The following is a description of a gene set: Foxp3+CD4+CD25+ regulatory T (T(reg)) cells are essential for the prevention of autoimmunity. T(reg) cells have an attenuated cytokine response to T-cell receptor stimulation, and can suppress the proliferation and effector function of neighbouring T cells. The forkhead transcription factor Foxp3 (forkhead box P3) is selectively expressed in T(reg) cells, is required for T(reg) development and function, and is sufficient to induce a T(reg) phenotype in conventional CD4+CD25- T cells. Mutations in Foxp3 cause severe, multi-organ autoimmunity in both human and mouse. FOXP3 can cooperate in a DNA-binding complex with NFAT (nuclear factor of activated T cells) to regulate the transcription of several known target genes. However, the global set of genes regulated directly by Foxp3 is not known and consequently, how this transcription factor controls the gene expression programme for T(reg) function is not understood. Here we identify Foxp3 target genes and report that many of these are key modulators of T-cell activation and function. Remarkably, the predominant, although not exclusive, effect of Foxp3 occupancy is to suppress the activation of target genes on T-cell stimulation. Foxp3 suppression of its targets appears to be crucial for the normal function of T(reg) cells, because overactive variants of some target genes are known to be associated with autoimmune disease. from publication Marson A, Kretschmer K, Frampton GM, Jacobsen ES, Polansky JK, MacIsaac KD, Levine SS, Fraenkel E, von Boehmer H, Young RA (PMID 17237765) Genes up-regulated by FOXP3 in both ex vivo and hybridoma cells. Human Gene Set: MARSON_FOXP3_TARGETS_UP species: Mus musculus, and this is the list of marker genes: SLC2A3, MALAT1, ENO3, S100A6, MYO1C, CD44, RGS16, CD81, PNP, MAPRE2, CSNK1D, HNRNPLL, TNK2, PDLIM2, NRIP1, STK10, EPHX1, RCSD1, NHERF1, RAC2 (NCBI Gene Id 5880), MCL1, VIM, IRF8, HACD3, LRRC8C, NCF4, DDIT4, PLIN2, CAPG, PSMB8, CELF2, RAMP1, PPM1B, ITGAV, ARHGAP9, TGFBR1, CRIP1, SERINC3, ETS1, RSRP1, ECM1, OSBPL9 (oxysterol binding protein like 9, NCBI Gene Id 79638), MBNL2, MKNK2 (MAPK interacting serine/threonine kinase 2), CYB5A, TNFRSF4, ITM2C, GM2A, HADH (hydroxyacyl-CoA dehydrogenase), SWAP70, SNX18, XCL1, CD24, NKG7, MYH9, SAMHD1, TIAM1, ZNF260, S100A4, SH3BGRL, PDZK1IP1, BASP1, CORO1A (NCBI Gene Id 11151), S100A10, CD2, EP300 (NCBI Gene Id 2033)